The following is a description of a gene set: A process that is carried out at the cellular level which results in the assembly, arrangement of constituent parts, or disassembly of cytoskeletal structures comprising actin filaments and their associated proteins in the postsynaptic actin cytoskeleton. studied in species Homo sapiens Human Gene Set: GOBP_POSTSYNAPTIC_ACTIN_CYTOSKELETON_ORGANIZATION, and this is the list of marker genes: DBNL, POTEF (POTE ankyrin domain family member F), SH3GL2, ACTG1, POTEI, FARP1, EZR, RAC3, POTEJ, ACTB, SRCIN1, POTEKP, POTEE, WASF2, ACTN2, NOS1AP, MYH10, ACTL8, CPNE6, ACTBL2